The following is a description of a gene set: Genes down-regulated in comparison of control microglia cells versus those 6 h after stimulation with IFNG. Microglial cells are resident macrophages in the central nervous system (CNS) and play a pivotal role in the innate and adaptive immune responses against microbial infections. The immune functions of microglia are regulated by a milieu of cytokines including interferon (IFN)-gamma. We here performed a series of experiments to acertain the transcriptional profile of human fetal microglial cells at 1, 6, and 24 h after IFN-gamma treatment. Primary human microglial cells were either untreated or treated with 200u/ml IFN-gamma. Affymetrix U133A chips were utilized. Four different tissue samples (B18, O, W, and Y20) were analyzed at the three time points. species: Homo sapiens Human Gene Set: GSE1432_CTRL_VS_IFNG_6H_MICROGLIA_DN from publication Rock RB, Hu S, Deshpande A, Munir S, May BJ, Baker CA, Peterson PK, Kapur V (PMID 16163375), and this is the list of marker genes: KCTD5 (NCBI Gene Id 91152), ACTR10, HLA-F, SP140L, GCH1, CERS6, P2RY14, DSC2, DDX60, CXCL10, APOL2, BMAL2, CALCOCO2, IFI44, TMEM126B, TMEM185B, C1S, PRPF3, CD53, MVP, UBE2A, SOCS1, VAMP5, LIMK2, GRAMD2B, GAS8, FUT4, NOD2, RAB20, IRF7, ADAR, BCAR3, PSMB8, CSF2RB, CNTN5, DNAJA1, HERC6, NBN, SP140, MCUB, RAB27A, SERPING1, UBE2L3, SRI, PARP12, GBP1, TAP1, SLAMF8, GBP2, FLT3LG (NCBI Gene Id 2323), SP110, IDO1, TNFSF10, RSAD2 (radical S-adenosyl methionine domain containing 2), IL15, CARS1, RNF24, C1RL, GDI2, GNG10, EDN1, TRAFD1, APOL1, STOM, PSME2, IFITM1, DDX21, TYMP, ASCC3, CYLD, CFB, IRF1, CASP7, ISG20, CD47, AIDA, STAP1, ISOC1, TOP1, TBX21, IL32, STX11, RBM34, ATF5, JUNB, UBXN4, CDS1, ALLC, APOL3, POLG, LYN, APOBEC3G, SAR1A, PHF11, MTHFD2 (NCBI Gene Id 10797), ATG3, ISG15 (NCBI Gene Id 9636), PSMB9, THOC2, DYNLT1, CES1, VPS54, HLA-E, PLEK, AKAP12, ACTR6, RCN1, PSMA2, SRP54, IFI44L (interferon induced protein 44 like), SMCO4, PLSCR1, ELAVL4, ARAP2, MED13L, LAMTOR3, SCARF1, RIGI, ZNF672, RALA, PDGFRA, MX1, GK3, LCP2, KPNB1, JAK2, RHOBTB3, HNRNPR, G3BP2 (NCBI Gene Id 9908), CTNS, ARF3, PSMA4, STAT6, PRRG4, APOL6, CXCL11, POLR3D, ICAM1, PLAAT4, WARS1, STAT3, VPS9D1, RBCK1, SECTM1, IL15RA, HLA-DRA, SLAMF7, PSMA3, TRIM26, HEG1, RBMS1, ESF1, GK, KARS1, RCVRN, SLC25A28, CIITA, RHBDF2, RNF114, IFIH1, SSB, SMCHD1, NECTIN3, LAP3, FUT1, TIA1, CCL8, GIMAP5, GSAP, CXCL9, IFIT5, PIM1, ELF4, SBNO2, SCO2, CASP4, MYOF, RALB, USP25, PANK2, RFTN1, LITAF, RNF19B, FCGR1BP, AGO3, CNDP2, LIG4, PPA1, VRK2, POMP, KIF2A, CTNNBL1, BAZ1A, ETV7, NMI, PDCD1LG2, KIAA0040, STAT1, C5orf15, TDRD7